The following is a description of a gene set: Genes having at least one occurrence of the motif NNNNNNRGNACRNNGTGTTCTNNNNNN in the regions spanning 4 kb centered on their transcription starting sites. This matches the AR transcription factor binding site V$AR_03 (v7.4 TRANSFAC). Human Gene Set: AR_03 studied in species Homo sapiens, and this is the list of marker genes: UVRAG, KCNH5, TNS2, CIART, KCNJ1, IP6K2, ADCY6 (adenylate cyclase 6), NSD1, RELCH, IKZF2, RAB1B, SREK1, HEPACAM2, TRIM63, CCDC6, ADNP, AMY2A, NLK, SLAIN1 (NCBI Gene Id 122060), SLC7A8, SDC1, ADGRB3, SMYD5 (SMYD family member 5), RBM24, DNAJB4, PHF21A, NCDN (NCBI Gene Id 23154), LARP4, ZP3, ITGA6, DLX3 (NCBI Gene Id 1747), USP54, WNT9A, PYGM, SYNCRIP, RANBP9, EPG5, KHDRBS1, JPH1, FSTL5, CXCL14, KLHL5, SPATA31G1, OTP, RERE, SLC9A1, BDNF, MAP4K5, RTL3, RCN1, NRGN, ZNF654, GSDMA, SMOX, SCNN1A, ELAVL4, CPEB4, BCL6